The following is a description of a gene set: studied in species Homo sapiens Human Gene Set: WP_HEDGEHOG_SIGNALING_WP47 Hedgehog signaling, and this is the list of marker genes: GLI2, SIN3A, SAP18, GLI1, GRK2, SUFU, BMAL1, KIF7, SMO, GLI3, IHH, DHH, PTCH2, PTCH1, STK36, SHH